Given this list of marker genes GNG12, GNG3, GNG5, GNG13, PIK3CG, AKT3, GNG8, MTOR, GNB4, GNB5, GNG7, GNB2 (NCBI Gene Id 96628), GNG11, GNG2, GNGT1, PIK3R5, AKT1, GNG10, AKT2, PIK3R6, GNG4, GNGT2, GNB1, GNB3, here is a description of the gene set: Human Gene Set: KEGG_MEDICUS_PATHOGEN_KSHV_VGPCR_TO_GNB_G_PI3K_AKT_SIGNALING_PATHWAY KSHV vGPCR to GNB/G-PI3K-AKT signaling pathway. Pathway ID: N00158. Pathway type: Pathogen. Pathway class: nt06224 CXCR signaling. Pathway Definition from KEGG: vGPCR -> GNB/G -> PI3Kgamma -> PIP3 -> AKT -> MTOR studied in species Homo sapiens